The following is a description of a gene set: Generation of movement along a single- or double-stranded DNA molecule, driven by ATP hydrolysis. Mouse Gene Set: GOMF_DNA_TRANSLOCASE_ACTIVITY studied in species Mus musculus, and this is the list of marker genes: Atrx, Fbh1, Ercc6l, Rad54b, Rad54l